Given this list of marker genes RIMS3, C1orf50, EDN2, MIR30C1, HEYL, RNA5SP47, ZMYM4, BMP8A, TFAP2E, PPIH, RPL12P45, LITATS1, RNU6-1237P, RPL36AP9 (NCBI Gene Id 100271139), RNF220, SFPQ, LINC02811, THRAP3, RNU6-510P, AGO4, MIR6735, KDM4A-AS1 (NCBI Gene Id 100132774), LINC02918, DYNLT4, RNU6-536P, EVA1B, COX7BP4, INPP5B-AS1, KIAA0319L, MED8, UTP11, EPHA10 (EPH receptor A10), BMP8B, TEKT2, RNU4-27P, DLGAP3, GUCA2A, RNU6-369P, ENSG00000284720, RPL5P4, ATP6V1E1P1, SNIP1, STK40, C1orf210, LINC02786, TMEM269-DT, ENSG00000284650, DPH2, MPL, TMEM69, RHBDL2, RN7SL479P, TESK2, MIR30E, ZMPSTE24, SMAP2, CLDN19, ZNF684, LSM10, RPS8, LINC01343, TRAPPC3, PTPRF, PTCH2, HIVEP3 (HIVEP zinc finger 3), GRIK3, C1orf216, RNU6-636P, RNU6-753P (RNA, U6 small nuclear 753, pseudogene), KLF17, TSPAN1, PRDX1, RNA5SP44, ELOVL1, MRPS17P1, LURAP1, CCDC24, RN7SL503P, HNRNPFP1, GUCA2B, RAD54L, DNALI1, RPL6P1, PLK3, RPL21P20, RNU6-584P, ZC3H12A, SNORA62, HYI-AS1, AKIRIN1, TMEM53, P3R3URF, SCMH1-DT, IPP, MEAF6, RNU6-605P, SLC2A1-DT, HYI, MANEAL (mannosidase endo-alpha like), ZFP69B, PPIE (NCBI Gene Id 10450), COL8A2, NCDN, FHL3, MIR6079 (microRNA 6079), SHMT1P1, ERI3-IT1, RPS3AP11, ZMYM1, SNORD46, KRT8P47, ADPRS, TRIT1, CDCA8, RNA5SP43, COL9A2, ZMPSTE24-DT, P3R3URF-PIK3R3, SLC2A1, KLF18, TIE1, SNORD38B, EBNA1BP2, CSF3R, MRPS15, MIR5581, HMGB1P48 (high mobility group box 1 pseudogene 48), ACTN4P2, CCDC17, ZMYM4-AS1, GJA9, AKR1A1, ENSG00000284719, NT5C1A, MMACHC, RNU7-121P, ZMYM6, FOXO6, POMGNT1, ZNF691, MACF1, MIR6732, EXO5-DT, RIMKLA, MIR6733, CDC20-DT, RPL23AP17, CCDC30, NFYC-AS1, HECTD3, P3H1, HSPE1P8, SNORA63 (small nucleolar RNA, H/ACA box 63), CFAP57, RNA5SP45, GJA4, TMEM35B, RSPO1, FTH1P1, SCMH1 (NCBI Gene Id 22955), RNU5D-1, PIK3R3, SLFNL1-AS1 (SLFNL1 antisense RNA 1), RN7SL326P, TMSB4XP1, ATP6V0CP4, CAP1, ZSWIM5, PPIAP36, UBE2V2P4, CFAP97P1, UROD, YRDC, OXCT2, MAP7D1, CDC20, GTF2F2P2, LINC01144, MIR5584, SZT2-AS1, BEST4, ENSG00000284895, MUTYH (mutY DNA glycosylase), RRAGC-DT, B4GALT2, GPBP1L1, RNU5F-1, ENSG00000307557, BMP8B-AS1, C1orf122, CCDC163, OOSP1P1, TMEM269, MYCL-AS1, PABPC4-AS1, MIR6734, POU3F1, EXO5, KDM4A, MFSD2A, NDUFS5 (NCBI Gene Id 4725), KCNQ4, CITED4, CCNB1IP1P1, MAST2, EIF2B3, FTLP18, UBE2V1P8, RNU6-880P, ST3GAL3, ERMAP, RPS27P9, MIR3659HG, PPCS, DMAP1, ENSG00000297367, SF3A3, PSMB2, OXCT2P1, MIR4255, BTBD19, ENSG00000261798, TMEM125, IPO13, ERI3, RNU6-608P, MTF1, FOXJ3, SVBP, MED8-AS1, AGO1, CLSPN, ZFP69, FOXO6-AS1, ARMH1, SH3D21, MIR552, NFYC, HPDL, RRAGC, SNORD38A, TMA16P2, RN7SL131P, PPIAP35 (NCBI Gene Id 128194), ATP6V0B, SMIM12, RPS29P6, GJB4, GPR199P, GJB3, AIRIM, KIF2C, GJB5, OSCP1, SNORA55, HSPA5P1, TFAP2E-AS1, RPS15AP11, CTPS1, MYCBP, LINC01685, ZMYND12, CFAP144, MYCL (MYCL proto-oncogene, bHLH transcription factor), RPS15AP10 (ribosomal protein S15a pseudogene 10), EFCAB14P1, INPP5B, OSTCP5, RNA5SP46, HPCAL4, SZT2, SNORA63C, NASP, SLFNL1, GNL2, YBX1, EIF1P2, SLC6A9 (solute carrier family 6 member 9), ST3GAL3-AS1, PPIEL, PABPC4, TMCO2, TOE1, MIR3659, OAZ1P1, ARTN, RNU5E-6P (RNA, U5E small nuclear 6, pseudogene), AGO3, SNORD55, RLF, ZNF691-DT, PPT1, MKRN8P, RPL7AP16, here is a description of the gene set: Human Gene Set: chr1p34 studied in species Homo sapiens